The following is a description of a gene set: species: Homo sapiens Astigmatism A type of refraction error associated with abnormal curvatures on the anterior and/or posterior surface of the cornea. Human Gene Set: HP_ASTIGMATISM, and this is the list of marker genes: DSE, MKKS, OVOL2, MPLKIP, FANCD2, GRIA1, CHST14, UBE3B, AGBL5, CRELD1, MBTPS2, RAD51C, SETBP1 (NCBI Gene Id 284262), TNPO2, LIG4, MIR184, COL4A1, WDPCP, BLOC1S3, TBC1D7, NFIX, CEP78, PALB2, AP3D1, GNPTAB, IFT172, ERCC2 (ERCC excision repair 2, TFIIH core complex helicase subunit), MAN2B1, ERCC4, HDAC4, BBS7, BAP1, RFWD3, YY1, TCF4, HGD, MAD2L2, POGZ, FANCI, GLRB, CCDC47, MAG, CHMP1A (charged multivesicular body protein 1A), PIK3R1, NIPBL, FANCL, EXOSC5, TARS1, TRIM37, FIBP (FGF1 intracellular binding protein), BBIP1, GRHL2, H1-4, EFEMP1, BBS10, CC2D2A, SCLT1, VSX1, GTF2E2 (NCBI Gene Id 2961), SETD5, TTC8, FANCF, GATAD2B, SLC38A8 (NCBI Gene Id 648732), RNF113A, POLR3GL, BBS4, RAP1B (NCBI Gene Id 5908), RHOA, MAP3K7, VARS1, ADNP, TBC1D2B, BRIP1, PITX2, ARID1B, PDZD8, COL1A2, FBN1, CAPRIN1, CLDN16, PRKAR1B, LMX1B, BRCA2, BBS1, AHDC1, SLX4 (SLX4 structure-specific endonuclease subunit), SLC4A11, ARSG, PBX1, FANCC, SLC2A10, BMP4, CAMSAP1, PPP2R5D, PIGT, ZMIZ1, MKS1, PIGQ, NRAS, ARPC4, IFT27, GALNT2 (polypeptide N-acetylgalactosaminyltransferase 2), TRIM32, CHST6, HARS1, TCEAL1 (NCBI Gene Id 96422), BBS12, DPAGT1, CACNA1F, FANCB, FANCM, KDM5B, ASH1L, ROBO3, EMC1, PAX2, ARHGEF2, ARCN1, RECQL4, ZBTB7A, SMG8, TGFBI, KAT6A, ANKRD11, CAMK2B, FANCG, CHD3 (NCBI Gene Id 1107), ZFX, TUB, COL9A3, NEUROD2, CLRN1, COL17A1, CAMTA1, RNU4-2, DYRK1A, TYR, ERI1, ERCC3, PPP1R12A, SHOC2, CLDN19, FANCA, PRMT7 (NCBI Gene Id 54496), SCAPER, KRAS, FBXW7, ARL6, SLC39A8, CARS1, XRCC2, ALDH3A2, IFT74, MYO1H, FANCE, MT-TS2, CLDN11, RERE, CEP290, MYT1L, KIF11, DNAJC21, CCDC28B, HK1, CEP19, BBS5, COL9A1, CHD4, SMARCAL1, GPR143, WAC, FLNA, AEBP1, DPYD, SLC25A24, USP9X, NOG, COL9A2, TFE3, CHRDL1, PIEZO2, STXBP1, RNU4ATAC, TBCE, BBS9, MBD5, APC2, PACS2, C1QBP, ZEB2, UBAP2L, SDCCAG8, NSD1, KMT2B, BBS2, CNGA3, RAD51, NPHP1, AARS1, EBF3, UBE2T, P4HTM, KCNV2, OTUD5, EDEM3 (NCBI Gene Id 87240), LZTFL1, GTF2H5, INTS1, CFAP418, ZEB1, BRCA1, INTS11, MAPK8IP3, RNF2, SCUBE3, KIDINS220, COL8A2, LMBRD2, TEAD1